The following is a description of a gene set: Mouse Gene Set: GOMF_STRUCTURAL_MOLECULE_ACTIVITY The action of a molecule that contributes to the structural integrity of a complex. studied in species Mus musculus, and this is the list of marker genes: Tnnt2, Gm5478, Mrps18a, Myl1, Reln, Mrpl37, Cryba2, Ltbp1, H1f1, Rpl3, Arc, Krt80, H2ab1, Odf2, Pclo, Lamb1, Dlg2, H2ax, Cldn6, Fbn1, mt-Rnr1, Epb41l3, Thbs4 (thrombospondin 4), Rplp1rt, Actn1, Sec31a, Mrpl43, Mrpl46, Copg2, Sprr1a (small proline-rich protein 1A), Tuft1, Rpl19, Rpl3l, Ndc1, Col8a1, Col22a1, Thbs1, Cldn1, Atp5f1d, Shank1, Sptbn1, Tubb2a, Bglap, Rpl39, Dnm3, Sprr2i, Col14a1, Sprr2e, Col6a3, Rpl24 (ribosomal protein L24), Hspb2, Crygn, Vps25, Mrpl17, Csrp2, Myl6, Col5a1, Mrps15, H2az1, Col16a1, Krt83, Cldn22, Creld1, Tuba8, Bsn, Rpl10l, Vim (vimentin), Cltc, Bmper, Krt71, Colq, Nup205, Tubb4a, Mrps23, Cryga, Homer1, Cmtm8, Krt14, Mrpl27, Tmem30a, Rps12, Rpl36al, Mrpl18, Mal, Ctnna2, Ntn1, Rpl7l1, Cpox, Tubal3, Slit2, Krt34, Myl2, Vwa1, Vwf, Col1a1, H1f0, Actn4, Matn4, Mrpl51, Col7a1, H2ap (NCBI Gene Id 67334), Lmnb2, Olfm4, Krt79, Rpl38, Dlg3, Krt26, Add1, Rpl26, Mrpl32, Krt10, Mbp, Prph, Crybb3, Rpl23, Krt84, Myom1, Sprr2a1, Cldn23, Mrpl9, Mrps2, Rps14, Pls3, Rapsn, Lmntd2, Pxdn, Cryge, Krt85, Krt28, Lmna, Mmrn2, Dcn (decorin), Macf1, Krt25, Cenpa, Lama3, Arpc1b, Rps11, Rps17, Krt87, Nefm, Dmbt1, Rpl27a, H2ac15, Col8a2, Capn3, Cldn16, Krt36, Krt7, Rps13 (NCBI Gene Id 68052), H2bc14, Rps6-ps4, Sprr2d, Mrps25, Rpl18a, Stx2, Mrpl16, Sntb1, H2ac10, H2al2b, Rps2, Septin7, Krt82 (keratin 82), Mrpl14, Plp1, Rpl37rt, Cldn3, Nup88, Loricrin, Rplp0, H2aj, Col12a1, Tuba1c, Mylpf, Col4a6, Bglap3, Tgm3, Dlg1, Rpl35, Krt77, Tln1, Mrps6, Arpc2, Dst, Mrpl41, Rpl15, Nup155, Tuba3a, Seh1l, H2bc9, Add2 (NCBI Gene Id 72970), Hmcn2, Rims3, Dmd, Mybpc3 (NCBI Gene Id 17868), Sec31b, Mybpc2, Col9a2, Rplp2, Krt17, Cryba1, Rpl37, Col6a2, Acte1 (actin, epsilon 1), Rpl9, Vcan, Gm10257, Rpl9-ps6, Muc2, Erc2, H2ac8 (H2A clustered histone 8), Crygs, Col10a1, Erc1, Krtap3-2, Rpl10, Fbln1, Fbln5, Rpl13a, Lim2, Nup98, Pom121l2, Mrps18c, Vwa5a, Flg, Hspb6, Cldn11, Rpl23a, Camk2b, Tubg1, Krt5, H2al1k, Pom121 (NCBI Gene Id 97245), Rps3, Rpl29, Rps27l, Crygc, Mrps18b, Nid1, Ina, Crygb (NCBI Gene Id 12965), Gfap, Ltbp2, Rpl7, Efemp1, Mrpl21, Cldn2, Sprr2g, Ltbp4, Mrpl52, Krtap3-1, Lamb3, Mfap4, Nup153, Mrpl36, Mrps14, Rpl28, Hp1bp3, Cryab, Krt78, Col18a1, Rpl14, Lama1, Krt86 (keratin 86), Emid1, Des, Rps23, Krt73, Col23a1, Rps27rt, Cryaa, Krtap3-3, B2m, Mrpl4, Csrp1, H2ac12, Sntg2, Git1, Col9a1, Rps15, Lamc2, Tcap, Panx1, Rpl34-ps2, Tubb1, Bglap2, Rpl41, Copg1, Rpl32l, Mpp2, Rpl10a, Rps7, Rps20, Lad1, Csrp3, H2al1j (NCBI Gene Id 640564), Nup160, Rpl36-ps12, Nefl, Rps21, Mrpl13, Ctbp2, Col17a1, Mip, Mrps16 (mitochondrial ribosomal protein S16), Uba52-ps, Krt31, Jph1, Gpm6b, Igf1r, Nup188, Prelp, Nup58, Krt18, Insr, Rps29 (NCBI Gene Id 328119), Ttn, Hapln1, Crocc, Rpl5, Panx3, H2bc1, Spon1, H2al1o, Mfap5 (microfibrillar associated protein 5), Sspo, Col2a1 (NCBI Gene Id 12824), Mrpl22, Rimbp2, Mrps10, Fga (fibrinogen alpha chain), Rpl36, Otol1, Papln, H3f5, Adipoq, Rpl17, Col13a1, Dpt, Fgb, Rps25, Rpl4, Cltb, H2ab3, Mrpl20, Snta1, Mrpl35, H2bc27, Tectb, Rpl8, Rps5, Crybb1, Actg1, H2ab2, Tubb3, H2bw2, Actr2, Lamb2, Mrps9, Krt222 (NCBI Gene Id 268481), Cldn17, Gm6133, Cope, Col11a1, Rpl11, Tube1, Mrps5, Rpl18, Krt33b, Rps6, Rps27, Creld2, Rpl35rt, Mrps22, Krt2, Tubb2b, Cldn7, Myom2, H2bc3, Crybb2, Macroh2a1, Rps24, Mrpl34, Pcolce2, Mobp, Dbnl, Krtap26-1, Rps28, Ctnnd2, Mrpl1, Krt16, Dsp, Col27a1, Mfap1a, Mrpl3 (mitochondrial ribosomal protein L3), Krt6a, Fn1, Tinagl1, Plec, Lmnb1, Igfbp7, H2bc22, Gm5414, Psmd13, Tecta, H2ac20, Rplp1 (NCBI Gene Id 80450), Mrpl2, Tuba1a, Eppk1, Mrps21, Mrpl23, Rpl37a, H2ac25, H1f5, Mfge8, Col3a1, Rps3a1, Mrps34, Cldn5 (claudin 5), H2al1e, Tnc, Rims1, H2al1b, H2al1m, Ogn, Lama5, H2ac24, Nefh, Hmcn1, Cldn18, Cldn14, Rpl34-ps1, Mrpl57, Uba52rt, Krt20, Mrps24, H2ac1, Lum, Col1a2, Rsl24d1, Copb1, Add3, Cldn9 (NCBI Gene Id 56863), Mrps31, Postn, Vtn, Srbd1, H2ac22, H2al1f, Pnpla1, H3f3c, Bgn, Mrpl12, Arpc4, H2bl1, Nup62, Mfap1b, H2bc12, Nup62cl, Col28a1, Bfsp2, Sptb, Evpl, Krt15 (NCBI Gene Id 16665), Tpm2, Krt9, Mrpl30, Dlgap1, Spock2, Tsga10, Rps18, H1f6, Psmd11, Col25a1, Cldn4, Rpl36a, Rpl6, Col6a5, Mall, Krt75, Pllp, Igfbp6, Krt72, Cldn8 (claudin 8), Col4a4, Zp1, Hmgcl, Sparc (NCBI Gene Id 20692), Emilin1, Actr3, Fau, Bfsp1, Nup93, Mrpl54, H2bc18, Hmox1, Cldn10, Mrps17, Rpl22l1, Tubb5, Copb2, Mrpl28, Scara3, Rims2, Krt90, Ppfia2, Hmga1 (high mobility group AT-hook 1), Krt19, Rps19, Rpl35a, Ubb, Sntb2, Tubb6, Rpl13-ps6, Krt33a, H2ac19, Krt76, Copa, Fbln2, H2ac6, H1f3, Rpl27, Nup107, Myh11, Marco, Krt74, Actn2 (actinin alpha 2), Mrpl39, Arpc3, Krt24, Col4a5, Krt6b, Krt39, Rps15a, Aspn, Srpx2, Matn2, mt-Rnr2, Crybg3, Rpl32, Magi2, Rpl34, Rpsa, Krt35, Emilin2, Tubd1, Lama4, Ctnna1, Col6a4, H2al3, Fras1, Rpl22, H2ac4, H3f4, Cryba4, Epb41l1, Nup85, H2bc26 (NCBI Gene Id 97778, H2B clustered histone 26), Oc90, Krt12, Amelx, Agrn, Cldn15, Rpl21, Epb41l2, Krt23, Vcl, Col19a1, Rpl6l, Panx2, Efemp2, Col6a1, Clta, H2ac11, Ncmap, Ambn, Col9a3, Mrps12, Dlg4, Ppl, Tuba4a, Krt13, Nup133, Krt4, Marveld1, Rps8, Mrps7, Rps4x, Col4a1, Rpl7a, Actb, H2ac13, Col4a2, Krt42 (NCBI Gene Id 68239), Mrps35, Mrpl55, Crygd, H2ac23, Rpl9-ps1, Lamc1, Sprr1b, Lama2, H2ac7, Nexn, Mrpl19, Mrpl10, Sntg1, H2al2a, Tpr, Dap3, H2bc21, Rps10, Rpl30, Mrps11, Rpl17-ps8, Mrpl15, Col24a1, Tln2, H1f4, Rps16 (NCBI Gene Id 30901), H2al1n, Shank2, Npnt, Nid2, H2az2, Ecm1, Macroh2a2, Tubb4b, Mrpl47, Arpc5, Rps27a, H1f8, Krt27, Enam, Mrpl45, Mfap2, Fbn2, Ank3, Col5a3, Dag1, Mrps30, Tuba1b, Bves, Prg2, Crygf, Rpl10-ps3, Rpl12, Pdlim3, Krt81, Col11a2, Eln, H3f3a-ps1, Cldn13, Mmrn1 (multimerin 1), H2ac21, Mrpl49, Hapln4 (NCBI Gene Id 330790), Rpl13, Shank3, Actbl2, Krt32, Mrpl33, Nup54, Cldn19, H1f2, Tgfbi, Rps9, Mrpl11, Krt1, Zp2, Zp3, Col5a2, Myl9, Rpl27rt, Rpl39l, Hspg2, Ank2, Mrpl24, H3f3a-ps2, Rps26, Rpl31, Krt40, Tpm1, Synm, Col15a1, Uba52, Fgg, Nup214, Gm6421, Col4a3, Mal2, Nup35, Myl6b, Epb41, Mybpc1, Otog, Comp, Sptbn2, Col6a6, Sec13 (NCBI Gene Id 67817)